Given this list of marker genes PLXNA3, ZMIZ1, UQCRQ, DISC1 (NCBI Gene Id 80138, DISC1 scaffold protein), ATP7A, SCYL2, FGFR2, DCLK2, FOXG1, SLC4A10, OGDH, here is a description of the gene set: Human Gene Set: GOBP_PYRAMIDAL_NEURON_DEVELOPMENT The progression of a pyramidal neuron from its initial formation to its mature state. studied in species Homo sapiens